Given this list of marker genes CORIN, NPR1, CES1, TBX5, NPPC, NPPA, KAT2B, HIPK1, HIPK2, WWTR1, GATA4, NPR2, NKX2-5, MME, here is a description of the gene set: Cardiovascular homeostasis can be regulated by natriuretic peptides. Reactome Pathway: Physiological factors part of: Cardiac conduction studied in species Homo sapiens